The following is a description of a gene set: Human Gene Set: GOBP_NEGATIVE_REGULATION_OF_PROTEASOMAL_PROTEIN_CATABOLIC_PROCESS studied in species Homo sapiens Any process that stops, prevents or reduces the frequency, rate or extent of proteasomal protein catabolic process., and this is the list of marker genes: ARHGAP5-AS1, BAG6 (BAG cochaperone 6), SGTA, UBXN1, SENP1, HSP90AB1, GABARAPL2, LAMP3, WAC, HFE, MARCHF7, TRIM39, USP14, MIR128-1, PSMF1, KLHL40, USP26, CCAR2, UBXN2A, MTM1, PHF20L1, SHH, BAG5, USP9X, NOP53, PABPN1L, USP38, SMARCC1, TTC36, FHIT, USP5, SVIP, PRKCG, F8A2, GIPC1, TLK2, USP7, UCHL5, PBK, F8A1, PSME3IP1, DDRGK1, ALAD, N4BP1, AQP11, OGT, OPHN1, CAMLG, EIF3H, RYBP, CSNK2A2 (casein kinase 2 alpha 2), PANO1, TAF9, USP25, MAP1A, PARK7, CSNK2A1, RPL11, F8A3, STYX, CSNK2B